The following is a description of a gene set: Human Gene Set: HP_APLASIA_HYPOPLASIA_AFFECTING_BONES_OF_THE_AXIAL_SKELETON Absence (due to failure to form) or underdevelopment of bones of the axial skeleton. Aplasia/hypoplasia affecting bones of the axial skeleton species: Homo sapiens, and this is the list of marker genes: FGFR1, FGF10, ARID2, SH2B1, PDE4D, TBCK, PEX19, PRORP, IGF1, BRD4, GTF2E2, ARL6IP6 (NCBI Gene Id 151188), COL3A1, CLPB, SYT2, XRCC2, PRKCZ, COL9A3, ABCD1, ALG14, DYNC2H1 (dynein cytoplasmic 2 heavy chain 1), B3GLCT, SCYL2, TBX1, FAM20C, STAG1, RUNX2, DDX3X, COMP, SUMF1, OSTM1, PEX11B, TOR1A, HOXB1, VPS33B, EXTL3, PKHD1, VPS13B, CHST3, CCDC22, RAD51C, TP63, FOXI3, ITGA7, RAF1, ELN, TELO2, BRAT1, SETD5, DKC1 (dyskerin pseudouridine synthase 1), PDE6D, PLCB4, CILK1, SLC5A7, TXNL4A, RFWD3 (ring finger and WD repeat domain 3), LEMD2, NIPBL, TMCO1 (NCBI Gene Id 54499), KIDINS220, GNPTAB, RPL11, ANKRD11, TMEM270, SP7, CSPP1, FKRP, PAM16, RECQL4, TMEM107, ZNF292, CRIPT, CEP55, TCOF1, LAMA5, TCTN3, FBXL3, RPS26, CHST14, PEX5, VARS1, YY1, DICER1, DPM1, NUP107, FLII, CANT1, NDUFB11, B3GALT6, NODAL, FLCN, SUPT16H, VPS35L, PI4K2A, ARVCF, DHCR24 (24-dehydrocholesterol reductase), RAB3GAP2, KIF21A, MMP2, CEP57, MYF5, WNK3, DYNC2LI1, THOC6, IGFALS, CHD8, CSGALNACT1, RAB3GAP1, BRCA2, TGDS, ARMC9, FBXW11, SSR4 (NCBI Gene Id 6748), GLI3, FBXL4, TRPV4, LEMD3, VANGL2, DPM2, PCGF2, PTDSS1, KDM5C, ORC1, BPTF, RPL5, PSAT1, MPLKIP, ATRX, SLC18A3, TOE1, MID1, WDR4, MYH7, TBCE, COL1A1 (collagen type I alpha 1 chain), DEAF1, OCRL, TWIST1, SH3PXD2B, EVC2, SETBP1, POLD1, C1R, RPL35, SIX6, KCNAB2, GBA1, SF3B2, FAT4, KAT6A, BAZ1B, LTBP4, MECP2, EBF3, P4HB, RTTN (rotatin), ZBTB18, ANAPC7, KLHL41, PIEZO2 (piezo type mechanosensitive ion channel component 2), TBC1D20 (NCBI Gene Id 170488), TGFB2, KMT2D, DSTYK, RMRP, EBP, ORC6, PIK3R1, TUBB3, SKI, POLE, PGM1, RPS27, COMT, HDAC9, RELN, TSR2, ALX4, EYA1, STX1A, MAPK8IP3 (NCBI Gene Id 89855), ERMARD, TAPT1, ERCC2, PIGO, MAP3K7, IARS2, ALPL, ERCC6, TAF6, COL6A3 (collagen type VI alpha 3 chain), SEC24D, SEMA5A, ACVR1, RB1, HSD17B4, TSEN54, RAB23, POLR1D, HIRA, GATA1, PEX26, DOCK6, PLA2G6, PLAA, ZIC3, CLCN3, FOXF1, GTF2IRD2, PAX1, NXN, OTX2, FANCD2, PTCH1, PCNT, MMP23B, RPL8, GRIP1, IFT172 (NCBI Gene Id 26160), PORCN, SPEN, PDPN, ALG12, SMAD3, OSGEP, EIF5A, PIGA, CSNK2A1, DYRK1A, DDRGK1, KCNK4, RHOBTB2, PSMC1, SCO2, PLXND1, AHDC1, TRIP11, FANCC, COL6A2, DVL3, INTS1, CREBBP, C12orf57, PEX10, WDR35, HEATR3, KDM4B, RAB34, RAB18, IFT80, CTBP1, SMOC1, EXT1, EDN1, PIGW, PQBP1, ATRIP, NF1, NSDHL, TBL2, ESCO2, MYMK, DVL1, TXNDC15, MSTO1, COG7, WLS, KCNK9, KRAS, HDAC8, INTU, FANCE, POGZ, GDF11, NDE1, SNIP1, CDC45, LRP4, UHRF1, HSPG2, RPL18, DCHS1, NUP133 (nucleoporin 133), AGA, LUZP1, TARS1, PLAG1, RPL31, SPRTN, DOK7, EP300, ARSB, FOCAD, CASZ1, RAD51, BUB3, ATPAF2, RPGRIP1L, ZNF699, TRPM3, AMMECR1, PHGDH, MAN2C1, WNT5A, GNAI3, KMT2A, MBD5, USB1, ADAMTS2, UNC80, PEX13, NEB, PRDM16, COG1, POR, STRA6, CARS1, MINPP1, POMT2, UBE3B, NKX3-2, CDCA7, FGD1, SPOP, SC5D, LIMK1, SMC3, RPS28 (ribosomal protein S28), TP53RK, PPP1R12A, NCAPG2, DPH1, TMEM237, COG8, PHF21A, FUZ, TPM2, ERCC5, B4GAT1, PEX14, HDAC6, ADA2, BMP4, SPRED1, ATP6V1B2, SOX9, SOX2, RPL9, ANK1, LMBRD2, FRAS1, RBM10, NSMCE2, NOTCH3, SFRP4, ASNS, TRAPPC2, GJA1, CAPRIN1 (cell cycle associated protein 1), HBA2, RAPSN, PIGV, TRAIP, MAFB, LIG4, GNS, PRDM13, COL13A1, TWIST2 (NCBI Gene Id 117581), HYOU1, KCNJ6, PSMB8, ACTA1, GON7, ERCC1, PIGF, GEMIN4, TCTN2, UPF3B, SIN3A, KIAA0586, IGF1R, B9D1, ROR2, SRCAP, MEG3, CHD7, HNRNPR, POLR1A, SIX1 (SIX homeobox 1), PIGT, HAAO, CHSY1, ORC4, PAH (phenylalanine hydroxylase), PPP3CA, MCTP2, LMNA (NCBI Gene Id 7816), HCCS, POMGNT1, SLX4, COASY, BICRA, RPS17, ARX, NBN (NCBI Gene Id 4683), CAMTA1, IQSEC2, SNRPN, SLC26A2, NFIX, GAD1, MAP3K20, CLIP2, CLCF1, SETD2, PDGFRB, SLC25A24, ACTG2, EPG5, BDNF, WNT3, IDUA, RDH11, BRCA1 (NCBI Gene Id 672), EFEMP2, RPL35A, TBXT, HNRNPU, DDR2, DPYD, NSUN2, FKBP6, WNT7A, DPAGT1, COL9A2, EMG1, FLNB, AEBP1, TRPV6 (NCBI Gene Id 55503), TBX15, IRX5, NALCN, PALB2, GTF2H5, WDR62, AFG2B (AFG2 AAA ATPase homolog B), SLC29A3, TPM3, ALX3, KIAA0753, MYH3, TFAP2A, STAC3, RASA2, PIGY, TRIP4, EDNRA, TNNT3, IPO8, GALNS, CENPJ (centromere protein J), TUBA1A, RPS15A (ribosomal protein S15a), YRDC, HES7, SOS1, PAX7, PLAGL1, PLK4, SCUBE3, LRPPRC, LBR, UBE2T, KIF26A, DZIP1L, TASP1, TMEM70, TBCD, RYR3, CHD5, CHN1, HACD1, APC, DYNLT2B, AIFM1, VPS53, TNRC6B, PLCB3, CA2, GPC3, DIS3L2, ARID1B, IHH, SLC25A19 (solute carrier family 25 member 19), CTU2, NSD2, CEP120 (centrosomal protein 120), VANGL1, TCTN1 (NCBI Gene Id 79600), ESAM, GMNN, CRLF1, RPS7 (NCBI Gene Id 6201), SHANK3, HECTD4, FANCM, PSPH, RNF113A, C2CD3, CCDC32, GJA5, TTN, MIPEP, VPS37D, CHUK, MSX2, SLC2A10, UBA1, NOTCH2, H3-3A, SMO, COL9A1, ASXL1, FBN1, SNRPB (small nuclear ribonucleoprotein polypeptides B and B1), KCNJ5, SLC25A1, SIM1, PEX12, B3GAT3, BICD2, CDK5 (cyclin dependent kinase 5), NSD1, MYCN, CTDP1, MYO18B, BRF1, RRAS2, PAK2, ERCC4, HUWE1 (NCBI Gene Id 54789), MYL2, RPS24, ALDH1A2, PEX6, BUD23, FANCB, RPS20, CRELD1, COL25A1, GNA11, BLTP1, RIPK4, CENPF, MRAS, INPPL1, CHAT (choline O-acetyltransferase), POC1A, MADD, CC2D2A, RAP1B, MAB21L1, WWOX, PEX2, CUL7, PTEN (phosphatase and tensin homolog), SPEG, AARS1, ATP7A, POMT1, MTX2, PIGQ, EIF4A3, GATA4, CACNA1C, LFNG, RPL27 (NCBI Gene Id 6155), PEX7, RINT1, COL12A1, TUBB, UFD1, CCN2, SERPINH1 (serpin family H member 1), RIT1, ADAT3, TBX3, SCARF2, AMER1, FZD2, WT1, GATAD2B, SMC5, NECTIN1, SMG8, ACTG1, LRRC32, SOS2, MYO9A, RRAS, MITF, CTSK, RAI1, MNX1, MAP2K1, RPL26 (NCBI Gene Id 6154), ALX1, DHODH, MAD1L1, PGAP3, SLC35B2, RNU4ATAC (NCBI Gene Id 57788), KYNU, GRB10, CLTCL1, SMC1A, ERGIC1, EIF4H, AGRN, FGF3, RFT1, DNAJC30, REV3L, CPLANE1, CTCF, DYM, RFC2, FKTN, ANKLE2, KNL1, FUCA1, TRPS1, RPL10 (NCBI Gene Id 88324), DONSON, MUSK, LGI4, DSE, LRP2, RPS19, NUP85, AFF3, ABCD4 (NCBI Gene Id 5826), SMAD2, ADGRG6, HYLS1, PUS1, XYLT1, PUS7, CCL2, RAD21, LAS1L, SF3B4, DNA2, CASK, BMPR1A, CD96, ZFX, COX7B, COL11A2 (NCBI Gene Id 494120), ALG9, NRAS, YARS1, RAB33B, PGAP2 (post-GPI attachment to proteins 2), H4C9, MAPK1, PRRX1, PEX1, MAD2L2, ZMIZ1, CREB3L1, NEDD4L, GPC4, LARGE1, PIEZO1, NAA10, TOMM7, GUSB, RERE (NCBI Gene Id 9642), COL1A2, ARSL (NCBI Gene Id 415), DNMT3B, RTL1, PRUNE1, PIGG, AFF4, SEC31A, DNAJC21, KPTN, CHRNA1, BRIP1, CTNND2, GHR, YARS2, DNMT3A, FANCG, EFTUD2, CPLX1 (complexin 1), LETM1, TOPORS, MAGEL2, KDM5A, BGN, ALG1, ZNF335, ZNF668, PYROXD1, RLIM, ALG13, TBX4, LONP1, ARCN1, PTPN11, GP1BB, RBBP8, EVC, FILIP1, FIG4, ATP6V0A2, CEP152, TBX5, XRCC4, GLE1, WASHC5, EZH2, MYPN, D2HGDH, LMOD3, KCNH1, ASXL3, HMX1, GLDN, ZC4H2, LAGE3, MKS1, TNNI2, FBXO11, SEC24C (SEC24 homolog C, COPII coat complex component), NRCAM, SHOX, ATP6AP2, KCNJ2, NELFA, CDC42BPB, GTF2I, SLC35D1, LZTR1, BPNT2, MARS1, SPRED2, SLC10A7, RAC3, FN1, GNPAT (glyceronephosphate O-acyltransferase), PI4KA, PKDCC, VAMP1, RSPO2, POLR1C, TRMT10A, POLR1B, LIFR, FGFR3 (fibroblast growth factor receptor 3), ZMPSTE24, KIF7, PEX3, EIF2AK3 (NCBI Gene Id 9451), CNOT2 (CCR4-NOT transcription complex subunit 2), FBXO28, TMEM67, BUB1 (NCBI Gene Id 699), KIF14, ATR, GPX4, TBC1D24, TGFBR1, RPS29, COG4, FGFRL1, PIGL, GJA8, HMGA2, KCNN3, SELENON, ACTB, ZNF341, PRKAR1A, TNFRSF11A, CENPE, B9D2, PURA, WDR11, PAICS, RPS10, PAX6, CWC27, NEK1, SIX2, BCL11A, VAC14, DYNC2I2, CBL, RNU4-2, JMJD1C (jumonji domain containing 1C), RREB1, BCOR, GSC, BCAP31, FGFR2, TRIM37, FDFT1, BCL11B, RARB, GNB2, MAPRE2, FANCL, TGFB3, DPYSL5, HRAS, EXT2, BMPER, ANTXR1, NOG, SNAP25, EMC1, PIGB, RPL15, PTH1R, ZDHHC9, TBX6, MYBPC1, CRTAP, KAT6B, B4GALT7, SMCHD1, IFT81, SCN4A, CHD4, HELLS, GOLGA2 (NCBI Gene Id 2801), NCF1, FLNA, PUF60, STAG2, ADGRG1, TRIP13, SOX6, TCIRG1, FLI1, ASPM, CDT1, DLK1, MED12, IRF6, PRIM1, HYMAI, COL6A1, BRAF, PIGN, NEK9, DPH5, LMX1B, DPH2, KDM6A, TRRAP, IGF2, FANCI, BANF1 (NCBI Gene Id 8815), SPECC1L, HOXD13, GPC6, OCLN, ERI1, PIK3CA, ROBO1, FBN2, HNRNPH2 (heterogeneous nuclear ribonucleoprotein H2), BUB1B, RBM8A, SATB2, RPGRIP1, FRA10AC1, ERBB3, EIF4A2, DNAI1, RIN2, GLB1, ZBTB24, IFT122, WDR73, PSMD12, DHCR7, IFT43, BLM, SRY, C1S, SLC37A4, KATNB1, TMEM231, DYNC2I1, CHD6, TMEM216, ADAMTSL2, IFT140, FANCA, FANCF, CDC6, EFNB1, CHRNG, SLC35A3, PLVAP, ATAD3A, COL5A1, TPRKB, PEPD, FLVCR2, METTL27, COL2A1, UBE4B, RNU12, SRPX2, TRIO, BMP2, GABRA3, POLR3A, AKT1 (NCBI Gene Id 207), CPE, GTF2IRD1, PPP1R15B, MYOD1, NUP88, GPKOW, CFL2, SALL4, PEX16, MYH8, ERCC3, PHIP (pleckstrin homology domain interacting protein), HBA1, MCM5, CBFB, CEP290, MYMX, AUTS2, NFASC, TGFBR2, CHRND, KBTBD13, FAM149B1, CEP295, TENT5A, FOXC2, SUZ12, COL11A1, ECEL1, WDR26, TAF1, CDKN1C, GABRD, CNTNAP1, OFD1